Given this list of marker genes Ccr6, Clasp1, Epb41l5, Glipr2, Vim, Ptk2, Arf6, Eppk1, Jun, Hbegf, Aqp1, Hyal1, Sash1, Cd63, Fgf7, Iqsec1, Mapre2, Hif1a, Ppm1f, Arsb, Enpp2, Itga3, Hdac6, Fgf10, Plcg2, Sema3a, Pten, Mcc, Dock1, Mtor, Src, Tacstd2, Ptpn23, Ptprr, Macf1, Insl3, Plcg1, Coro1c (NCBI Gene Id 23790), Sox9, Adam9, Dusp10, Tgfb2, Serpine1, Rab25, Evl, Irs1, Dab2ip, Tgfbr2, Ptprg, Tacr1, Prkce, Bmpr2, Pfn1, Clasp2, Ifng, Has2, Gab2, Rab11a, Dock5, Rtn4, Marveld3, Macir, Scrib, Tgfbr3, Mmp9, Tac1, Adipor1, Irs2, Itga2, Rreb1, Pfn2, Arhgap5, Apc, Vil1, Map4k4, Capn7, Il4, Ctsh, Epb41l4b, here is a description of the gene set: Mouse Gene Set: GOBP_REGULATION_OF_EPITHELIAL_CELL_MIGRATION studied in species Mus musculus Any process that modulates the frequency, rate or extent of epithelial cell migration.